Given this list of marker genes ATF2, MAP3K8, MAPK8, CREB1, USP14, IKBKG, PPP2CB, MAPK14, NLRC5, BTRC, SKP1, PPP2R1A, TIFA, TRAF2, MAP2K1, IRAK2, MAPK1 (mitogen-activated protein kinase 1), TLR5, PELI3, RIPK2 (NCBI Gene Id 8767), APP, MEF2C, CASP8, MYD88, NKIRAS2, TAB1, UBE2N (ubiquitin conjugating enzyme E2 N), fliC, MAPK9, CHUK (component of inhibitor of nuclear factor kappa B kinase complex), UBE2V1, IKBIP, IKBKB, TP53, NOD2, MAP2K3, MAP2K6 (mitogen-activated protein kinase kinase 6), PELI1, RELA, NLRX1, DUSP6, TRAF6, DUSP3, CUL1, S100B (NCBI Gene Id 6285, S100 calcium binding protein B), RPS6KA1, MAP3K1, PELI2, TNIP2, AGER, UBA52, NOD1, ATF1, NKIRAS1, UBB, USP18, MAPK3, TLR10, FBXW11, N, DUSP4, VRK3, MAPK7, MEF2A, MAP2K4 (NCBI Gene Id 6416), MAP2K7, IRAK1, NFKBIA, FOS, S100A12, TAB3, MAP3K7, RPS6KA2, MAPKAPK2, RPS27A, TAB2, MAPK11 (mitogen-activated protein kinase 11), ALPK1, N4BP1, PPP2R5D, MAPK10, DUSP7, ELK1, RPS6KA5, ECSIT, IRAK4, MAPKAPK3 (NCBI Gene Id 7867), LRRC14, NFKBIB, SAA1, PPP2CA, NFKB2, HMGB1, PPP2R1B, NFKB1 (NCBI Gene Id 4790), UBC, JUN, RPS6KA3 (NCBI Gene Id 6197), here is a description of the gene set: species: Homo sapiens Reactome Pathway: Toll Like Receptor 10 (TLR10) Cascade part of: Toll-like Receptor Cascades Little is known about TLR10 ligands. It has been established that the receptor homodimerizes upon binding and signals in an MyD88-dependent manner (Hasan U et al 2005; Nyman T et al 2008). It may also heterodimerize with TLRs 1 and 2. It is expressed in a restricted fashion as a highly N-glycosylated protein detectable in B cells and dendritic cells.